The following is a description of a gene set: Human Gene Set: DESCARTES_MAIN_FETAL_INHIBITORY_INTERNEURONS species: Homo sapiens Marker genes curated from the annotated cluster as represented in the Descartes Human Gene Expression During Development database. from publication Cao J, O'Day DR, Pliner HA, Kingsley PD, Deng M, Daza RM, Zager MA, Aldinger KA, Blecher-Gonen R, Zhang F, Spielmann M, Palis J, Doherty D, Steemers FJ, Glass IA, Trapnell C, Shendure J (PMID 33184181) The gene expression program underlying the specification of human cell types is of fundamental interest. The study authors generated human cell atlases of gene expression and chromatin accessibility in fetal tissues. For gene expression, the study authors applied three-level combinatorial indexing to >110 samples representing 15 organs, ultimately profiling ~4 million single cells. The study authors leveraged the literature and other atlases to identify and annotate hundreds of cell types and subtypes, both within and across tissues. Our analyses focused on organ-specific specializations of broadly distributed cell types (such as blood, endothelial, and epithelial), sites of fetal erythropoiesis (which notably included the adrenal gland), and integration with mouse developmental atlases (such as conserved specification of blood cells). These data represent a rich resource for the exploration of in vivo human gene expression in diverse tissues and cell types., and this is the list of marker genes: PBX3, EPHA8 (EPH receptor A8), ADARB2-AS1, GAD1, LHX5, MYT1L-AS1, LINC02144, ENSG00000253857, DISP3, MGAT4C, SH3GL2, ANO4, KIT, MSRA, UNC5C, GLCE, SKOR1, SLC30A3, NEUROG2, RNU6-729P, CPLX4, AJAP1 (adherens junctions associated protein 1), CDH22, FNDC1-IT1, CHL1, SLC6A5, GAD2, XKR4 (NCBI Gene Id 114786), ROBO3, BHLHE22, ENSG00000226939, HCRTR2, PRSS51, SLC35F4